Given this list of marker genes Capza1b, Lmod2, Twf2, Capza1, Dbnl, Specc1l, Tmod4, Eps8, Swap70, Capg, Tmod1, Capza2, Scin, Spta1, Add3, Tmod3, Arpc2, Capzb, Tmod2, Dmtn, Cracd, Mtpn, Capza3, Shroom2, Pik3ca, Plekhh2, Flii, Evl, Carmil2, Sptb, Rdx, Gsn, Lmod1 (NCBI Gene Id 93689), Twf1, Svil, Add1, Tpm1, Carmil1, Sptbn1, Lmod3 (leiomodin 3 (fetal)), Lima1, Vill, Vil1, Add2, Sptan1, Cfl1, Myh9, Avil, here is a description of the gene set: studied in species Mus musculus Mouse Gene Set: GOBP_NEGATIVE_REGULATION_OF_ACTIN_FILAMENT_DEPOLYMERIZATION Any process that stops, prevents, or reduces the frequency, rate or extent of actin depolymerization.